Given this list of marker genes Tsr3 (TSR3 20S rRNA accumulation), Trabd2b, Utp23, Wdr43, AA414768, Hnrnpdl, Mthfd2l, Ubap1, Sik3, Ogn, Cd93 (CD93 antigen), Ldlrad4, Mdga1, Pllp, Nr3c2, Spg21, Gldc, Tbl1xr1, Teddm1b, Cables2, Zdhhc7, Gm21190, Tppp, Josd2, Map3k13, Nrxn2, Atl2, Sash1, Noa1 (NCBI Gene Id 67056), Crem, Fut11, Hgs, Pcdh17, Atrn, Marcksl1, Cd86, 1700034J05Rik, Trim24, Hr, Chrm3, Spn, Zdhhc20, Trpm3, Esp18, Rhbdl3, Zmym2 (zinc finger, MYM-type 2), Tspan7, Ampd2, Ankle1, Vmn2r37, Neo1, Cox16 (NCBI Gene Id 75664), Tmie, C1ql3, Tes, Zbtb34, Atp2b1, Ifit2, Atp2a2, Scd1, S2bpcox16, Xxylt1, Mau2, Cplx1, Grik3, here is a description of the gene set: Genes predicted to be targets of miRBase v22 microRNA mmu_miR_3095_3p in miRDB v6.0 with MirTarget v4 prediction scores > 80 (high confidence targets). from publication Chen Y, Wang X (PMID 31504780) studied in species Mus musculus Mouse Gene Set: MIR_3095_3P